Given this list of marker genes DDRGK1, MIR520A, CDK10, PAGR1, CENPJ, AIF1, CDC6, PAF1, PLCG2, MIR29A, PKP3, RRM1, RPTOR, TERT, GLI1, TP63, MBLAC1, CCND1, MIR515-1, MEPCE, KMT2E, MDM2, CYP1A1, PLCB1, MIR372, ANXA1, CRNN, MTBP, AKT1, UBE2E2, LSM11, ANKRD17, NANOGP8, STIL, SASS6, MIR495, KCNA5, MIR208A, STOX1, PTENP1-AS, LSM10, MIR519D, EIF4G1, DDX3X, CDC73, FGF10, ADAMTS1, MIR221, MIR520H, MIR222, ADAM17, MIR214, STXBP4, TFDP1, DDR2, CUL4A, RRM2, PLRG1, EGFR, CCND3, RDX, CPSF3, FAM83D, RGCC, CUL4B, CCND2, TBX2 (T-box transcription factor 2), EZH2, CCNE2, CCNE1, here is a description of the gene set: Any signaling pathway that activates or increases the activity of a cell cycle cyclin-dependent protein kinase to modulate the switch from G1 phase to S phase of the cell cycle. studied in species Homo sapiens Human Gene Set: GOBP_POSITIVE_REGULATION_OF_CELL_CYCLE_G1_S_PHASE_TRANSITION